Given this list of marker genes TNFSF10, ATP6V0E2, ZNF22, ERICH4, RBP2, BHMT, SLCO2B1, SLC6A4, LGALS2, CYP4F3, AKR1D1, KANK4, SULT1C2, UNC93A, SLC13A5, MEP1A, ABHD2, ACSM2B, BDH1, HLMR1, SOAT2, IL22RA1, CYP19A1, IFNLR1, PLA2G12B, ABCG8, DIO1, SLC47A1, MUC20, FABP1, here is a description of the gene set: from publication Sumi K, Tanaka T, Uchida A, Magoori K, Urashima Y, Ohashi R, Ohguchi H, Okamura M, Kudo H, Daigo K, Maejima T, Kojima N, Sakakibara I, Jiang S, Hasegawa G, Kim I, Osborne TF, Naito M, Gonzalez FJ, Hamakubo T, Kodama T, Sakai J (PMID 17403900) Human Gene Set: SUMI_HNF4A_TARGETS Cholesterol homeostasis is maintained by coordinate regulation of cholesterol synthesis and its conversion to bile acids in the liver. The excretion of cholesterol from liver and intestine is regulated by ATP-binding cassette half-transporters ABCG5 and ABCG8. The genes for these two proteins are closely linked and divergently transcribed from a common intergenic promoter region. Here, we identified a binding site for hepatocyte nuclear factor 4alpha (HNF4alpha) in the ABCG5/ABCG8 intergenic promoter, through which HNF4alpha strongly activated the expression of a reporter gene in both directions. The HNF4alpha-responsive element is flanked by two conserved GATA boxes that were also required for stimulation by HNF4alpha. GATA4 and GATA6 bind to the GATA boxes, coexpression of GATA4 and HNF4alpha leads to a striking synergistic activation of both the ABCG5 and the ABCG8 promoters, and binding sites for HNF4alpha and GATA were essential for maximal synergism. We also show that HNF4alpha, GATA4, and GATA6 colocalize in the nuclei of HepG2 cells and that a physical interaction between HNF4alpha and GATA4 is critical for the synergistic response. This is the first demonstration that HNF4alpha acts synergistically with GATA factors to activate gene expression in a bidirectional fashion. Genes up-regulated in HepG2 cells (hepatocellular carcinoma, HCC) upon expression of HNF4A and down-regulated upon knockdown of HNF4A in these cells by RNAi. studied in species Homo sapiens